The following is a description of a gene set: studied in species Homo sapiens CSF lymphocytic pleiocytosis An increased lymphocyte count in the cerebrospinal fluid. Human Gene Set: HP_CSF_LYMPHOCYTIC_PLEIOCYTOSIS, and this is the list of marker genes: PRRT2, ATP1A2 (NCBI Gene Id 93186), TBK1, IRF3, TREX1, TRAF3, SCN1A, ADAR (adenosine deaminase RNA specific), RNASEH2B, TICAM1, RNASEH2C, LSM11, UNC93B1, IFIH1, RNU7-1, TLR3, SAMHD1, RNASEH2A (NCBI Gene Id 10535), CACNA1A